Given this list of marker genes CALR, ATF6, HSPA5, MBTPS1, NFYB, DDIT3, NFYC, XBP1, NFYA, HSP90B1, MBTPS2, ATF4, here is a description of the gene set: Human Gene Set: REACTOME_ATF6_ATF6_ALPHA_ACTIVATES_CHAPERONES studied in species Homo sapiens ATF6 (ATF6-alpha) activates chaperones